Given this list of marker genes RN7SKP200, ATP6V1E1P3 (ATPase H+ transporting V1 subunit E1 pseudogene 3), RNU6-406P, RPL9P29, MSH2, E2F5, CNN2P9, here is a description of the gene set: from publication Yevshin I, Sharipov R, Kolmykov S, Kondrakhin Y, Kolpakov F (PMID 30445619) Human Gene Set: ZNF211_TARGET_GENES Genes containing one or more binding sites for (ZNF211) in their promoter regions (TSS -1000,+100 bp) as identified by GTRD version 20.06 ChIP-seq harmonization. species: Homo sapiens